Given this list of marker genes Grb2, Fgf20, Hras, Fgfr4, Fgf16, Klb, Fgf6, Fgf23, Shc1, Fgf17, Kras, Fgf4, Fgf2, Sos1, Fgf8 (fibroblast growth factor 8), Fgf9, Fgf15, Fgf18, Fgf1, here is a description of the gene set: SHC-mediated cascade:FGFR4 species: Mus musculus Mouse Gene Set: REACTOME_SHC_MEDIATED_CASCADE_FGFR4